The following is a description of a gene set: Deubiquitination of H2AK119. Pathway ID: N01585. Pathway type: Reference. Pathway class: nt06523 Epigenetic regulation by Polycomb complexes. Pathway Definition from KEGG: PR-DUB -| cPRC1 studied in species Homo sapiens Human Gene Set: KEGG_MEDICUS_REFERENCE_DEUBIQUITINATION_OF_H2AK119, and this is the list of marker genes: CBX8, SCMH1, ASXL2, RING1, SCML2, MBD6, PHC2, PHC3, OGT, CBX4, YY1, ASXL3, CBX2, ASXL1 (NCBI Gene Id 23393), CBX6, PCGF2, FOXK2, HCFC1, FOXK1, SCML1, MBD5, CBX7, PHC1, RNF2, BAP1, BMI1